Given this list of marker genes PRKAA1, PRKAB2, CSN2, EIF4G1, PRKAA2, RPS6KB1, RPTOR, EIF4A2, MTOR, CSN1S1, EEF2K, TSC2, MLST8, EEF2, EIF4E, PRKAG3, CSN3, PRKAG2, PRKAG1, PRKAB1, here is a description of the gene set: studied in species Homo sapiens AMPK regulation of mammary milk protein synthesis Human Gene Set: WP_AMPK_REGULATION_OF_MAMMARY_MILK_PROTEIN_SYNTHESIS